Given this list of marker genes AIF1L, RAC1, PSD4, TESC, TWF1, RASGRP2, PLEKHA1, PDPN, CFL1, C2CD5, SPRY2, KANK1, EPS8L1, PLA2G4F, SNTG1, ABCA7, EPS8L3, PAK1, THEM4, TPM1, NME1, SRC, EZR, ARF4, SPRY4, ITGA5, PDE9A, MYO1C, SPATA13, EEF1A1 (eukaryotic translation elongation factor 1 alpha 1), RHOA, PACSIN1, PIP5K1A, PSD, ARHGEF4, PSD2, PIP5K1C, MACF1, CIB1, CLCN3, CLASP2, PACSIN2, ARHGEF2, ITGAV, RPS3, ITGB1, PLEKHO1, DLC1, HIP1R, KSR1, LCP1, INPP5K, FAP, MTSS2 (NCBI Gene Id 92154), IFIT5, TRPV4, APPL2, FGR, RAB34, MYO6, DIAPH1, TLN1, ERBB2, FGD5, MTMR6 (myotubularin related protein 6), MTMR9, ADAM17, PLCG1, EPHA2, APC, PLEK, PLCG2, ARHGAP45, AIF1, CDKL5 (NCBI Gene Id 6792, cyclin dependent kinase like 5), FERMT1, EGFR, EPB41L5, EPS8L2, WWC1, SH3YL1, TIRAP, AKT2, FGD2, PTPRJ, PPP1R9B, SH3BGRL3, SH2D3C, BMX, ITGB3, PDE4A, CORO1C, RIGI, PSD3, KCNN4, PDXP, JCAD, NF2 (NF2, moesin-ezrin-radixin like (MERLIN) tumor suppressor), ADGRE2, FAM107A, EPS8, here is a description of the gene set: The portion of the plasma membrane surrounding a ruffle. studied in species Homo sapiens Human Gene Set: GOCC_RUFFLE_MEMBRANE